Given this list of marker genes NHERF1, SLC6A13, SLC6A11, SLC7A14, SLC32A1, SLC6A6, SLC6A8, SLC6A12, SLC6A1, here is a description of the gene set: Enables the transfer of gamma-aminobutyric acid from one side of a membrane to the other. Gamma-aminobutyric acid is 4-aminobutyrate (GABA). species: Homo sapiens Human Gene Set: GOMF_GAMMA_AMINOBUTYRIC_ACID_TRANSMEMBRANE_TRANSPORTER_ACTIVITY